Given this list of marker genes Sdc3, Dcn (NCBI Gene Id 13179), Cspg5, B3gat1, Gpc2, Bgn, B3galt6, Xylt1, Sdc1, B3gat3, B4galt7, B3gat2, Gpc3, Xylt2, here is a description of the gene set: electronically inferred by orthology from the curated human pathway Reactome Pathway: Glycosaminoglycan-protein linkage region biosynthesis part of: Glycosaminoglycan metabolism This event has been computationally inferred from an event that has been demonstrated in another species.<p>The inference is based on the homology mapping from PANTHER. Briefly, reactions for which all involved PhysicalEntities (in input, output and catalyst) have a mapped orthologue/paralogue (for complexes at least 75% of components must have a mapping) are inferred to the other species. species: Mus musculus